Given this list of marker genes IP6K2, RYBP, SAMSN1, HNF1A, AHSA2P, ILK, AP1S2, CDK6, IER5, CRTC2, HSD3B7, SPTB, TNFSF15, TOMM20, UNC13D, INO80, MLLT6, FOXD2, RGS3, CD83, PHF20, KLK9, NFKBIB, TSLP, IFNB1, DDR1, BMF, BDNF, CXCL2 (NCBI Gene Id 2920), RNF43, VSX2, RFX5, TCF15, UBE2I (ubiquitin conjugating enzyme E2 I), PCSK2, C1QL1, GJB1, BHLHE40, DNAJB5, RUNX1, LRP1, PFN1, KCNT2, ASH1L, RBM14, VCAM1, PRRG4, ACTN1, RBPJ, MARCKSL1, SLAMF8, PIK3IP1, ARHGAP44, CGN, NFKB2, GNAO1, BCOR, CD86, PRKCD, SOX5, CDC14A, RAP2C, PNKD, SIN3A, TGFB1, NFAT5, REL, STON2, TCEA2 (transcription elongation factor A2), PARP8, G3BP1, NLK, YY1AP1, SPEN, P2RY10, PABPC1, EP300, ATP1B1, LIX1L, ZHX2, HOXB3, PDZRN4, LINC01138, SMG7, SLC50A1, ZNF384, ATF5, PTGS2 (NCBI Gene Id 5743), ST8SIA1, LASP1, TANK, IRF2BPL, FGF17, FAM117A, TNFSF4, ZNF593, EHF, TFE3, TNFSF18, PAPPA, MNT, PLAU, ERN1, SPIB, PTGR3, FANCC, ICAM1, MAG, CXCL10, NOL4L, GBA2, PCDH10, CADM1, RRP8, TP63, MAML2, DAP3, GPR150, ZNF232 (NCBI Gene Id 7775), GRK5, PAFAH1B3, CCN2, CXCL9, HCFC1 (host cell factor C1), CHD4, PLA1A, STIP1, GATA4, CD40, SCAMP1, CREBZF, OGG1, PSMA1, RXRB, IL4I1, TSPAN2, HOXB9, SP6, ABRAXAS2, HHATL, WNT10A, TRIM47, IGF2BP1, HOXA7, ZBTB9, ASCL3, PTGIR, CYP26A1, PTPRJ, CYLD, MIR17HG, GREM1, ARHGEF2, CEND1, BCL3 (NCBI Gene Id 602, BCL3 transcription coactivator), SEC14L2, STX4, CPLX2, GABRE, PCBP4, UACA, CDC42SE1 (NCBI Gene Id 56882), TOP1, IL1RN, HSP90B1, MED1, CCN1, XPO1, PTHLH (parathyroid hormone like hormone), MLLT11, NSD1, CLTRN, NIPBL, CTAGE4, XPO6, PTGES, TASL, CD70, PRDM12, PDE3B, PLEKHS1, PDE4C, LTB, ADAMTS5, LUC7L3, SLC11A2, NOB1, GRIK2, WRN, VEZF1, SOX10, IL23A, MSC, LMO4, MOB3C, FOXS1, ACTR1A, NLGN2 (NCBI Gene Id 57555), CYBB, CCL5, EBF1, SLC39A7, MAP3K8 (mitogen-activated protein kinase kinase kinase 8), TIAL1, NFKBIA, HOXA11, CFAP69, RIN2, SCAF4, TRIB2, ATP1B3, FXYD2, CACNA1E, SUFU, BAZ2B, ANKHD1, NDRG2, ANKHD1-EIF4EBP3, TNIP1, NFKBID, NOS1, NUP62, STC2, CCDC102A, SLC6A12, STAT6, SEMA3B, ZNF423, ELOVL6 (ELOVL fatty acid elongase 6), RGL1, CLCN1, SYT7 (synaptotagmin 7), CCDC107, RAI1, ARPC5, TAL1 (TAL bHLH transcription factor 1, erythroid differentiation factor), SLC16A4, EPHA2, CSF2, SATB1, IL2RA, PPP1R13B, XKR8, NR2F2, AAMDC, CXCR5, AMOTL1, BCKDK, PLXDC2 (NCBI Gene Id 84898), LMO3, PURG, FGF1, JAK3, BFSP1, BNC2, RND1, HOXB2, RSF1, here is a description of the gene set: Human Gene Set: NFKB_Q6 Genes having at least one occurrence of the motif NGGGGAMTTTCCNN in the regions spanning 4 kb centered on their transcription starting sites. This matches the transcription factor binding site V$NFKB_Q6 (v7.4 TRANSFAC). species: Homo sapiens